Given this list of marker genes SOX2, PARD3, NTS, NOTCH3, HHEX, OR51E1, HMGA2, here is a description of the gene set: Despite studies that show the antitumor activity of Hsp90 inhibitors, such as geldanamycin (GA) and its derivative 17-allylamino-demethoxygeldanamycin (17-AAG), recent reports indicate that these inhibitors lack significant single-agent clinical activity. Resistance to Hsp90 inhibitors has been previously linked to expression of P-glycoprotein (P-gp) and the multidrug resistant (MDR) phenotype. However, the stress response induced by GA treatment can also cause resistance to Hsp90-targeted therapy. Therefore, we chose to further investigate the relative importance of P-gp and the stress response in 17-AAG resistance. Colony-forming assays revealed that high expression of P-gp could increase the 17-AAG IC(50) 6-fold in cells transfected with P-gp compared with parent cells. A549 cells selected for resistance to GA overexpressed P-gp, but verapamil did not reverse the resistance. These cells also overexpressed Hsp27, and Hsp70 was induced with 17-AAG treatment. When the GA and 17-AAG resistant cells were transfected with Hsp27 and/or Hsp70 small interfering RNA (siRNA), the 17-AAG IC(50) decreased 10-fold compared with control transfected cells. Transfection with siRNA directed against Hsp27, Hsp70, or Hsp27 and Hsp70 also increased sensitivity to EC78, a purine scaffold-based Hsp90 inhibitor that is not a P-gp substrate. We conclude that P-gp may contribute, in part, to resistance to 17-AAG, but induction of stress response proteins, such as Hsp27 and Hsp70, by Hsp90-targeted therapy plays a larger role. Taken together, our results indicate that targeting of Hsp27 and Hsp70 should be exploited to increase the clinical efficacy of Hsp90-directed therapy. studied in species Homo sapiens Genes down-regulated in A549GARS cells (lung cancer) resistant to the geldanamycin and 17-AAG. from publication McCollum AK, TenEyck CJ, Stensgard B, Morlan BW, Ballman KV, Jenkins RB, Toft DO, Erlichman C (PMID 18794130) Human Gene Set: MCCOLLUM_GELDANAMYCIN_RESISTANCE_DN